The following is a description of a gene set: Genes negatively differentially expressed in cell type: pDC (plasmacytoid dendritic cell) upon treatment with cytokine: IL-1α in mouse lymph nodes in vivo. from publication Cui A, Huang T, Li S, Ma A, Pérez JL, Sander C, Keskin DB, Wu CJ, Fraenkel E, Hacohen N (PMID 38057668) species: Mus musculus Mouse Gene Set: CUI_PDC_IL1A_RESPONSE_DN Cytokines mediate cell-cell communication in the immune system and represent important therapeutic targets. A myriad of studies have highlighted their central role in immune function, yet we lack a global view of the cellular responses of each immune cell type to each cytokine. To address this gap, the authors created the Immune Dictionary, a compendium of single-cell transcriptomic profiles of more than 17 immune cell types in response to each of 86 cytokines (>1,400 cytokine-cell type combinations) in mouse lymph nodes in vivo. A cytokine-centric view of the dictionary revealed that most cytokines induce highly cell-type-specific responses. For example, the inflammatory cytokine interleukin-1β induces distinct gene programmes in almost every cell type. A cell-type-centric view of the dictionary identified more than 66 cytokine-driven cellular polarization states across immune cell types, including previously uncharacterized states such as an interleukin-18-induced polyfunctional natural killer cell state., and this is the list of marker genes: Ncoa1, Timp2, Khk, Runx2, Pafah1b3, Ptp4a3 (protein tyrosine phosphatase 4a3), Bmyc, Mvb12a, Ccnd1, R3hdm4, Ighm, Ctsb, Ldhb, Ccr2, Btg2, Cd180, Bri3, Cd28, Cmah, Zeb2, Cdip1, Mef2c, Trf, Sms, Fyn, Sema4b, Ypel3, Ctsl, Nsa2, Hs3st1, Bst2 (NCBI Gene Id 97478), Atp1b1, Rgs2, Ppfia4, Clec12a, Smim5, Upb1, Pacsin1, Spns3, Klf2, Tsc22d1, Gnas, Ramp1, Arhgap17, Abhd6, Septin11